Given this list of marker genes Tyro3, Pdgfra, Ptger4, Fzd4, Sgpl1, Chrna7, Zfp830, Nppc, Pde4d (NCBI Gene Id 320753), Fshb, Sirt1, Mdk, Notch1, Casp2, Edn2, Adamts1, Has1, Lhcgr, Has2, Esr2, Scaper, Ptx3, Kiss1, Enpp2, Slc26a6, Slit3, Gas2 (NCBI Gene Id 14453), 2610005L07Rik, Ereg, Mmp2, Npr2, Stat5a, Zp3, Src, Nrip1, Agt, Nos3, Lep, Egr1, Pgr, Stat5b, Oxtr, Sohlh2, Amh, Oas1d, Adrm1, Ptn, Igf1r, Nr5a1, Gdf10, Nhlh2, Grk2, A2m, Runx1, Serpinf1, Map2k6, Ncoa1, Inhba, Myh9, Axl, Ptprn, Casp3, Tnfaip6, Cyp1b1, Adnp, Gabrb1 (gamma-aminobutyric acid type A receptor subunit beta 1), Arrb1, Pcna, Hspa8, Mmp19, Bmpr1b, Npy5r, Mstn, Afp, Esr1, Pla2g4a, Erbb2, Egfr (epidermal growth factor receptor), Cckbr, Retn, Nr5a2, Arrb2, Fshr, Gpr149, Plekha1, Schip1, Gdf9, Foxo3, Nos2, Mfn2, here is a description of the gene set: The type of sexual cycle seen in females, often with physiologic changes in the endometrium that recur at regular intervals during the reproductive years. studied in species Mus musculus Mouse Gene Set: GOBP_OVULATION_CYCLE